Given this list of marker genes XRCC3, DNASE2, GEN1, EME2, EME1, SLX1A, TEFM, MUS81, DNASE2B (deoxyribonuclease 2 beta), SLX1B, RAD51C, here is a description of the gene set: Catalysis of the hydrolysis of ester linkages within deoxyribonucleic acids by creating internal breaks to yield 3'-phosphomonoesters. Human Gene Set: GOMF_DNA_ENDONUCLEASE_ACTIVITY_PRODUCING_3_PHOSPHOMONOESTERS studied in species Homo sapiens